The following is a description of a gene set: Human Gene Set: COREBINDINGFACTOR_Q6 species: Homo sapiens Genes having at least one occurrence of the motif TGTGGTTW in the regions spanning 4 kb centered on their transcription starting sites. This matches the CBFA2T2, CBFA2T3 transcription factor binding site V$COREBINDINGFACTOR_Q6 (v7.4 TRANSFAC)., and this is the list of marker genes: ARMCX1, BATF3, ELAVL3, PRR5L, CD6, EIF2B3 (NCBI Gene Id 8891), VRK1, SLC12A6, KRTAP6-3, MPL, FOXF2, LUZP1, FAM117A, LRP5, HOXB4, MIA2, SLC26A7, DACT1, STON1-GTF2A1L, ASCL4, ANXA8, TLCD5, KCNJ1, UBE2E1, HOXD12, PDZK1, CYP17A1, AP5B1, HHIP, ENPP1, RORC, TGM4, HOXB6, RPA3, HDAC9, PROKR1, SLC32A1, RUNX1, CFAP20, IL3, CD69, CRTAC1, PICALM, EMP1, FDCSP, ETF1, ZFHX3, SGIP1, CSMD3, UBALD2, KRT73, TAGAP, BATF, PPP1R12C, ADD1 (NCBI Gene Id 118), SCNN1A, RUNX2, COL9A2, MAP1LC3A, WWC2-AS2, ARHGAP15, NRAS, GSK3B, EIF5A, VASN (vasorin), PHF6, BCAR3, IL13, DRD3, TBX5, MAFG, TMEM86A, SRSF4, NDUFA9, CALR, HEY1, ARHGAP33, NGB, SHOX2, CADM1, NAPSA, WNK4, GABRA6, SASH3 (SAM and SH3 domain containing 3), TP63, MIR22HG, HLX, PTPRS, ORMDL3, TLE3, RABGAP1L, TMEM62, PPP1R14C, BOC, UBL3, SEPTIN9, WDR81, RYBP, COL4A2, PAFAH1B1, PDE3B, SCN2A, BLOC1S1, NRSN1, MTX1, EVI2A, SELENOH, TMEM109, STAT2, CACNA2D3, XCL1, PGF, ENPP2, ARF3, NUTF2, UQCRFS1 (NCBI Gene Id 7386), CD101, ARHGAP45 (NCBI Gene Id 23526), CYTIP, ACVR2A, LINS1, LUC7L, TSSK2 (NCBI Gene Id 25785), NR4A3, THBS3, PITPNC1, PTPN22, PDGFC, KRT10-AS1, OTP, KCTD15, BTG4, IL17RE, ATP2A2, LY9, TBK1, SLC37A4, EDC4, SCRN1 (NCBI Gene Id 9805), TMEM101, RGS1, TIGIT, CCL3, COL4A1, MOSMO, IL23A, NFIX, RASSF2, C1orf198, NAV3 (neuron navigator 3), FKBP14, PDZD2, B3GNT5, MEIS2, CHAD, FOXP3, EPC2, LPO, MYL3, HOATZ, ZBTB8A, SP6, SULF1, RGMA, LRMDA, ARHGAP12, ENTPD3, LIF, SUPT4H1, EYA1, RILPL1, DIABLO (diablo IAP-binding mitochondrial protein), JMJD1C, RTL3, CBL (Cbl proto-oncogene), TAFAZZIN, TACSTD2, CRTC2, MAP3K11, PIGV, SPIB, TRPM8, PDZRN4, LRATD1 (LRAT domain containing 1), MEIOB, MADD, TMEM151A, PHOX2B (paired like homeobox 2B), NRXN1, STON1, RAMP2, CYGB, EPB41L3, ITGB7, NFKBIZ, S100A9, CNTD1, TMEM215, SOST, ASB7, RAG1, OTOGL, SREBF2, SLA2, DNHD1, FCER1G, SLC36A2, ITGB1BP2, TSC22D3, FGD1, RNF43, HOXC6, NR4A1, GPX1, FOXN3, C1QTNF6, LINC00310, ANK3, SLC37A2 (NCBI Gene Id 219855), LINC00649, AZIN1, SYT9, CPNE1, MDGA2, PSMA1, LTBP1, MKRN3, IL7R, PPARG (peroxisome proliferator activated receptor gamma), CD28, ACIN1, MMP13, GPR171, DYNLL1, ERG, SOX5, GPD1, TNFSF4, FLI1, CCL4, RGS18, COA3, KCNV2, TUBB4A, RHOG, HOXC4, SNTB2, VIM (NCBI Gene Id 7431), GRAP2, JDP2, EIF3J, CCR1, BMPR2, MSI2, GZMB, XCL2 (NCBI Gene Id 82261), LMO2, LEMD2, RNF19B, BMPR1B, NHLRC2, SUPT16H, RIN1, RAB39A, PAX6, NSUN4, PTK2B, LINC01931, SLC2A3, STRC, C14orf119, SDF2L1, TMEM117, ARHGEF2, MPO, HPCAL1